Given this list of marker genes Kcnj8, Prdm16, Inhbb, Syap1, Igf1, Mir448, Ifrd1, Hnrnpu, Ap1s2, Fabp3, Atat1, Ankrd26, Atf2, Ccn4, Ppard, E2f1, Ifrd2, Sav1, Clip3, Aldh6a1, Bmp2, Ffar4, Senp2, Fermt2, Sh3pxd2b, Lep, Steap4, Lama4, Cntnap2, Zbtb16, Pdgfra, Gata2, Sirt2, Plcb1, Sox8, Fitm1, Adrb3, Sult1e1, Creb5, Wfdc21, Cntn2, Selenbp1, Fto, C1ql4, Wnt5b, Rarres2, Noc3l, Insig1, Gdf6, Lpl, Sfrp2, Tfap2b, Socs7, Sdf4, Sort1 (sortilin 1), Fitm2, Zfp423, Gm15222, Adgrf1, Smad3, Plac8, Fgf10, Asxl1, Tcf7l2, Dysf, Zfp36, Egr2, Noct, Negr1, Scd1, Nr4a1, Gnb3, Zbtb7a, Aloxe3, Adipoq, Bscl2, Zfp36l1, Fam120b, Socs1, Srebf1, Metrnl, Arl6, Asxl2, Cmklr1, Mir188, Cebpb, Ptgr3, Cby1, Htr2a, Fosl2, Bbs1 (NCBI Gene Id 52028), Crebl2, Dio2, Tbl1x, Arxes2, Bbs2, Klf5, Eif2ak3, Lncbate1, Yap1, Sod2, Creb1, Foxo1, Ccdc85b, Dusp10, Vstm2a, Htr2c, Trpm4, Snai2, Frzb, Fbn1, Aamdc, Nr4a2, Osbpl11, Tbl1xr1, Cidea, Cebpd, Arid5b, Id4, Lamb3 (NCBI Gene Id 16780), Napepld, Slc7a10, Pias1, Hmga2, Tmem120b, Per2, Arl4a, Mkx, Mb, Gps2, Lrp6, Nipbl, Dkkl1, Lmo3, Ctbp1, Rnasel, Glis1, Bmp7, Sox13, Rorc, Pparg, Wnt1, Hdac6, Atf5, Stk3, Jag1, Zbtb7b, Angptl8, Ctbp2, Pex11a, Bbs9, Zbtb7c, Trio, Taf8, Ucp1, Mkks, Mettl8, Fndc3b, Arxes1, Carm1, Wnt10b, Medag, Gpr180, Cebpa, Itga6, Klf4, Axin2, Enpp1, Tgfb1i1, Nudt7, Opa3, Lrrc8c, Ttc8, Ptprq, Gpx1, Bcl2l13, Tnf, Fcor, Osbpl8, Lncbate10, Alms1, Fabp4, Zfpm2, Mmp11, Uchl3, Fbxo9, Ddit3 (NCBI Gene Id 13198), Adrb1, Zfp385a, Ffar2, Adrb2, Trib2, Bnip3, Six1, Zc3h12a, Adig, Ptgs2, Trim32, Flcn, Bltp1, Npr2, Zfp516, Ift88, Dlk1, Ebf2, Ccnd1, Tmem64, Sfrp1, Id2, Bmal1, Slc39a13, Gsk3b, Ccdc3, Ncor2, Wdfy2, Mecom, Pim1, Xbp1, Mtor, Mapk14, Retn, Bmncr, Fndc5, Trib3, Sh2b2, Gdf10, Jdp2, Alox5, Adgrf5, Tgfb1, Lrp3, Prlh, Mrap, Bbs7, Stk4, Mex3c, Dact1 (dishevelled-binding antagonist of beta-catenin 1), Rgs2, Gdf3, Dlk2, Lrg1, Psmb8, Zfp36l2, Ep300, Nr4a3, Nucb2, Bbs4, Smad6, Retreg1, Trpv4 (NCBI Gene Id 80591), Tfe3, Slc2a4 (NCBI Gene Id 20528), Vegfa, Tph1, Nr1d1, Msx2, Tmem120a, Grk5, Wif1, Gper1, Wnt3a, Bbs12, Cds1, Sirt6, Hes1, Tlcd3b, Lrp5 (low density lipoprotein receptor-related protein 5), Axin1, Med1, Runx1t1, Rora, Sirt1, Wnt5a, Ero1a, Akt1, Gm15290, Lpin1, Dhrs7b (dehydrogenase/reductase 7B), Rreb1, Wwtr1, here is a description of the gene set: Mouse Gene Set: GOBP_FAT_CELL_DIFFERENTIATION The process in which a relatively unspecialized cell acquires specialized features of an adipocyte, an animal connective tissue cell specialized for the synthesis and storage of fat. studied in species Mus musculus